Given this list of marker genes Fkbp1a, Lynx1, Igfbp2, Dut, Angpt2, Lrpap1, Ly6c2, Wfikkn1, Clec12b, Lypd1, Ly6i, Ly6e, Ly6c1, Lilrb4a, Ly6f, Ly6g6d, Lypd6, Ccl5, Ly6g2, Dkk1, Ly6a (lymphocyte antigen 6 family member A), Lilrb4b, Dkkl1, Adh7, Slurp2, Dkk4, Igsf1, Ly6g6g, Fst (NCBI Gene Id 99160), Pcsk9, Il1rn, Wfikkn2, Dkk3, Dkk2, Ly6g, Mtrnr2l7, Ly6h, Ly6m, here is a description of the gene set: Mouse Gene Set: GOMF_SIGNALING_RECEPTOR_INHIBITOR_ACTIVITY Binds to and modulates the activity of a signaling receptor. studied in species Mus musculus